The following is a description of a gene set: Human Gene Set: DAZARD_RESPONSE_TO_UV_NHEK_DN Genes down-regulated in NHEK cells (normal keratinocytes) by UV-B irradiation. from publication Dazard JE, Gal H, Amariglio N, Rechavi G, Domany E, Givol D (PMID 12771951) To gain insight into the transformation of epidermal cells into squamous carcinoma cells (SCC), we compared the response to ultraviolet B radiation (UVB) of normal human epidermal keratinocytes (NHEK) versus their transformed counterpart, SCC, using biological and molecular profiling. DNA microarray analyses (Affymetrix), approximately genes) indicated that the major group of upregulated genes in keratinocytes fall into three categories: (i). antiapoptotic and cell survival factors, including chemokines of the CXC/CC subfamilies (e.g. IL-8, GRO-1, -2, -3, SCYA20), growth factors (e.g. HB-EGF, CTGF, INSL-4), and proinflammatory mediators (e.g. COX-2, S100A9), (ii). DNA repair-related genes (e.g. GADD45, ERCC, BTG-1, Histones), and (iii). ECM proteases (MMP-1, -10). The major downregulated genes are DeltaNp63 and PUMILIO, two potential markers for the maintenance of keratinocyte stem cells. NHEK were found to be more resistant than SCC to UVB-induced apoptosis and this resistance was mainly because of the protection from cell death by secreted survival factors, since it can be transferred from NHEK to SCC cultures by the conditioned medium. Whereas the response of keratinocytes to UVB involved regulation of key checkpoint genes (p53, MDM2, p21(Cip1), DeltaNp63), as well as antiapoptotic and DNA repair-related genes - no or little regulation of these genes was observed in SCC. The effect of UVB on NHEK and SCC resulted in upregulation of 251 and genes, respectively, and downregulation of genes in NHEK and genes in SCC. To further analyse these changes, we used a novel unsupervised coupled two-way clustering method that allowed the identification of groups of genes that clearly partitioned keratinocytes from SCC, including a group of genes whose constitutive expression levels were similar before UVB. This allowed the identification of discriminating genes not otherwise revealed by simple static comparison in the absence of UVB irradiation. The implication of the changes in gene profile in keratinocytes for epithelial cancer is discussed. studied in species Homo sapiens, and this is the list of marker genes: SH2B3, CUL1, ADORA2B, KAT6B, FNBP1L, PTK2, CASP8, BUB1B, GAPVD1, SLC25A44, CDYL, SCAF11, VEGFC, BCL7A, CDKN1B, ARID3A, AKR1C3, CCNB2, HMGA2, DOCK4, CENPA, SART3, SMC5, DTX2, ASXL1, POLE2, ID1, PPIP5K2, FNDC3A, NFE2L2, DKK1 (dickkopf WNT signaling pathway inhibitor 1), MICB, GCLC (glutamate-cysteine ligase catalytic subunit), PUM2, SMC4, RNF13, PMS1, HIVEP2, WAPL, DYRK2, NCK1, MEGF9, ICE1, SLBP, NAV3, XPO1, FLG, N4BP1, TMCC1, UBL3, FEM1B, FAT1, AFF1, BAZ2B, UBR5, PIK3R4, SPOP, KIF2A, MAP3K5, CEBPD, HMGXB4, CBFA2T2, RRP1B, SSBP2, PUM1, EXPH5, ATRX, PPRC1, HELZ, TLK1, MTM1, FRYL, CYTH1, LPCAT1, GNE, BIRC2, VPS13B, KIAA0232, LPCAT4, MN1, JARID2, CHD1, SATB1, GSE1, ENOSF1, MNT, NUP153, IRS1, E2F3, IFI44L, ZMYND8, SMAD3, WDR37, DOCK9, ABL1 (NCBI Gene Id 25), PHIP, SP3, NFYA, DDIT4, ZNF318, ELF2, RCHY1, UBE2G1, ATP13A3, USP24, POLD3 (DNA polymerase delta 3, accessory subunit), BAZ1B, MDC1, MPHOSPH10, INSIG2, PAFAH1B1, PHF3, EDRF1, BTBD3 (NCBI Gene Id 22903), ORC2, E2F5, PTPN3, SLC25A36, NAA20, ZNF638, CEP170, MTMR6, LPP, ERBB3, TRIM13, MTUS1, MBD2, ZMIZ1, ZNF264, VPS13A, KIF14, NPAT, TOGARAM1, BACH1, MECP2, CCNE1 (cyclin E1), ADCY9, TLE4, PLK4, ADSL (NCBI Gene Id 158), BICRAL, ELF1 (NCBI Gene Id 1997), NEMP1, ZCCHC14, CNOT2, DYRK1A, ZFC3H1, ADGRL2, PRSS12, DMTF1, PHLPP1, ZZZ3, QKI, PRKCD, WDR82, AUTS2, FGFR2, MKI67 (NCBI Gene Id 4288), MAML1, SLC9A6, NR2F2, VLDLR, XPA, PIKFYVE, MLH3, LSM14A, CEP350 (centrosomal protein 350), CCDC93, RBPJ, MEIS1, LARP7, WWC1, FOXO1, SUCO, APPBP2, SHOC2, MORC3, TAF5L, WDHD1, NCOA3, ZNF148, FYN, SPEN, MICAL2, NPIPB5, KDM5A, RABGAP1L, PPP1R12A, INSIG1, HEG1, ATP2B1, BCAR3, METTL18, DST, SACS, TIPARP, PNISR, ZHX2, AHDC1, AJAP1 (adherens junctions associated protein 1), AGO2, CHD9, CPEB3, CLASP1, TUBGCP3, RIF1, MARCHF6, CNOT4, MTIF2, TTC9, USP6, TLK2, SMAD5 (NCBI Gene Id 4090), FOXJ3 (forkhead box J3), ADNP (activity dependent neuroprotector homeobox), ZBED4, DUSP7, OTUD4, ZNF217, MED13L, KEAP1, USP1, TP63, SKAP2, AKAP9, PALM2AKAP2, GJB3, BRD8, ZNF44, TENT4A, MYC, REV3L, KBTBD2, NPAS2, DIDO1, CENPF, CCNB1, RRS1, SERTAD2, FERMT2, PCF11, RAPGEF5, MTCL1, TUT4, TMEM131L (transmembrane 131 like), BBX, MAST4, CENPC, PPP1R3C, KLHL9, NFKB1, CREB3L2, PER2, KANK1 (NCBI Gene Id 23189), POGZ, PHC2, CBLB, CREBBP, PIK3C3, TNFAIP8, CTBP2, BAZ1A, ZC3H4, SLC7A1, FOXO3, ATF2, TAF11, PSD3, ZBTB24, ZNF451, KAT6A, KIF11, BPTF, KLF9, CERS6, STRN, RSBN1, EFNB2 (NCBI Gene Id 1948), DOP1A, WEE1, TOP2A, IGF2BP3, NRIP1, ARID5B, USP6NL, FAT2, ADRB2, KIF23, RAPGEF2, CTCF, SMAD7, DIO1, PUDP (pseudouridine 5'-phosphatase), AURKA, AHR, PIP4K2B, ARHGEF7, ZNF146, KLF7, WDFY3